The following is a description of a gene set: Mouse Gene Set: GOBP_PROSTATE_GLAND_MORPHOGENESIS studied in species Mus musculus The process in which the anatomical structures of a prostate gland are generated and organized., and this is the list of marker genes: Notch1, Rarg, Hoxd13, Tnc, Sulf1, Igf1r, Nkx3-1, Cd44, Fem1b, Ar, Esr1, Rxra, Nog, Bmp4, Cyp7b1, Foxa1, Frs2, Hoxb13, Hoxa13, Bmp7, Shh, Mmp2, Igf1, Trp63, Wnt5a, Fgf10, Sfrp1 (secreted frizzled-related protein 1), Stat5a, Serpinb5, Esr2, Fgfr2, Id4, Gli2, Sox9